Given this list of marker genes MIR30C2, COL19A1, ENSG00000221345, COL9A1, CD109-AS1, KHDC1L, OGFRL1, KHDC1P1, EEF1A1, LMBRD1, SDCBP2P1, CD109 (NCBI Gene Id 135228), RPSAP41, FAM135A, OOEP, LYPLA1P3, SMAP1, GAPDHP42, PAICSP3, KHDC1, KCNQ5-DT, KNOP1P4, SDHAF4, RNU7-48P, ENSG00000287300, RIMS1, FAM135A-AS1, KHDC1-AS1, SLC17A5, RNU4-66P, EEF1A1-AS1, SLC25A6P6, KRT19P1, NDUFAB1P1, RPL37P15, TXNP7, RN7SL827P, CGAS, RBPMS2P1, DDX43, BECN1P2, RPS27P15 (NCBI Gene Id 100271118), B3GAT2, RNU6-411P, ENSG00000223786, MTO1, MIR4282, MIR30A, FAM136FP, KHDC3L, NGRNP2, LINC01626, OOEP-AS1, LINC00472, NUP50P4, LINC01610, PGAM1P10, RNU6-975P, KCNQ5, DPPA5, ENSG00000272243, NPM1P37, EIF3EP1, KCNQ5-AS1, RPL39P3, RPS6P8, here is a description of the gene set: studied in species Homo sapiens Human Gene Set: chr6q13